The following is a description of a gene set: studied in species Homo sapiens Human Gene Set: GOCC_CALCIUM_CHANNEL_COMPLEX An ion channel complex through which calcium ions pass., and this is the list of marker genes: PKD1, RYR1, CACNA2D4, SESTD1, FKBP1B, CACNB2, CATSPER3, CACNA1G, CATSPERZ, PKD1L1 (polycystin 1 like 1, transient receptor potential channel interacting), MCU, CALM3, CACNA1A, CACNA1B, CATSPERE, TMEM249, CACNA1C (calcium voltage-gated channel subunit alpha1 C), MICU2, CACNB1, CATSPERD, CALM2 (calmodulin 2), CATSPERB, TRPV6, HSPA2, TRPC5, PDE4B, CACNG1, CATSPER4, TRPC4 (transient receptor potential cation channel subfamily C member 4), CATSPERG, RYR3, TMEM262, CACNA1D, TRPV5, STAC3, CACNA1E, EFCAB9, ATP2A1, FKBP1A, CALM1, CACNG2, CACNA2D3, MCUB, CACNG4, ASPH, SMDT1, PTPA, CACNA2D2, CATSPER1, PDE4D, CACNA2D1, MICU1, PKD2L1, CACNA1S, PRKACA, MICU3, CACNA1I, CACNG3, CATSPER2, CACNB3, CACNG6, CASQ2, CACNA1F, CACHD1, AKAP6, CACNG8, RYR2, CACNG7, CACNA1H, CACNB4, C2CD6 (C2 calcium dependent domain containing 6), ORAI1